The following is a description of a gene set: species: Homo sapiens The reproductive developmental process whose specific outcome is the progression of an oviduct over time, from its formation to the mature structure. An oviduct is a tube through which an ova passes from the ovary to the uterus, or from the ovary to the outside of the organism. Human Gene Set: GOBP_OVIDUCT_DEVELOPMENT, and this is the list of marker genes: CSMD1, CTNNB1, C3, ERRFI1, LHX1, WNT7A